The following is a description of a gene set: A transmembrane protein complex composed of an MHC class II alpha and MHC class II beta chain, and with or without a bound peptide or polysaccharide antigen. studied in species Mus musculus Mouse Gene Set: GOCC_MHC_CLASS_II_PROTEIN_COMPLEX, and this is the list of marker genes: H2-Eb2, H2-DMb1, Cd74, H2-Ab1, H2-Ea, H2-Aa, H2-Oa, H2-DMa, H2-DMb2, B2m, H2-Ob, H2-Eb1